The following is a description of a gene set: Genes predicted to be targets of miRBase v22 microRNA hsa-miR-3074-5p in miRDB v6.0 with MirTarget v4 prediction scores > 80 (high confidence targets). Human Gene Set: MIR3074_5P from publication Chen Y, Wang X (PMID 31504780) studied in species Homo sapiens, and this is the list of marker genes: SLC35E1, ZNF644, ZBTB8A, EPB41L4B, PHKB, EPB41L1, LHFPL3, ZNF618, YWHAB, TNFSF13B (NCBI Gene Id 89794), BAHD1 (NCBI Gene Id 22893), LRRC4, GAS2L3, SLC12A2, DCX, SMURF1, CENPS-CORT, SMURF2, ZNF626, TXLNB, ZNF704, FBXO3, G3BP1, YIPF1, TGFBR2, VGLL4, CEPT1, GTF2A1, MESD, ZNF302, ZNF827, PAG1, KLK10, MEIS1, PHIP, POU3F2, SMG1, CIT, PCDHB12, JPH4, MFSD1, MXRA7, TNKS2, PRAMEF18, PTPN4, PABIR1, ATG2B, MEFV, DIP2B, CTNNA3, SGCD (sarcoglycan delta), PRRC2B, CACNB2, MAP2, NIBAN1, PTGIS, TMEM248, EHMT1, TMEM86A, NDFIP1, IGF2BP1, MTMR12, NR4A3, MMAB, NDUFA4, TNRC6B, RELN, PIP4P2, UPF1, PALD1, TLCD4, GTDC1, PBX1 (PBX homeobox 1), GAD1, THBS2 (thrombospondin 2), FKBP7, SLC9A6, ITPRIP (NCBI Gene Id 85450), HOOK3, AMBN, R3HDM1, GAP43, KCNB1, ERO1A, SMIM10L1, ADAMTS17, BNC2, MOB1B, ADAT2, GABBR2, HPRT1, PDE4D, SLC38A4, KCNA6, AKTIP, PHACTR3, SYPL1, CNR1, KIF1B, GNG2, VANGL1, NF1, SRGAP1, ZNF516, TMEM154, KIF26A (NCBI Gene Id 26153), THADA, DKK2, ONECUT2, SIX4, ADSS1, PPM1A, VAPA, CRIM1, ZNF268, SBF2, STMN1, ADHFE1, CASP7, BICD2, RAPGEF6, CLCF1, ANO5, GRIA4, MCM9, EBP, HOXA11, APOO, CNEP1R1, HERC3, OOSP2, COMMD4, RIOK2, MFSD6, SLC7A11, PCDH20, TRIB2, MICALL1, DLST, PAFAH1B2, KCNJ15, NECAB1, TNIK (NCBI Gene Id 23043), BMP7, PROKR2, TENM1, UBE4A, SLC35A3, GPRIN3, KDM6A, ZDHHC5, CNTNAP2